The following is a description of a gene set: Human Gene Set: FAN_EMBRYONIC_CTX_BIG_GROUPS_INHIBITORY from publication Fan X, Dong J, Zhong S, Wei Y, Wu Q, Yan L, Yong J, Sun L, Wang X, Zhao Y, Wang W, Yan J, Wang X, Qiao J, Tang F (PMID 29867213) species: Homo sapiens, and this is the list of marker genes: TCF4, DLX1 (NCBI Gene Id 1745), PLS3, SOX2-OT, CXCR4, DLX2, ERBB4, DCX, GAD1, DLX5, PFN2, PDE4DIP